Given this list of marker genes Ntf3, Pcsk6 (proprotein convertase subtilisin/kexin type 6), Furin, A2m, Pzp, Ngfr, Ntrk1, Sort1, Nradd, here is a description of the gene set: Mouse Gene Set: GOMF_NERVE_GROWTH_FACTOR_BINDING species: Mus musculus Binding to nerve growth factor (NGF).